Given this list of marker genes Slc41a1 (NCBI Gene Id 98396), Trpm7, Kel (NCBI Gene Id 23925), Tmem94, Xk, Edn3, here is a description of the gene set: studied in species Mus musculus Mouse Gene Set: GOBP_INTRACELLULAR_MAGNESIUM_ION_HOMEOSTASIS A homeostatic process involved in the maintenance of a steady state level of magnesium ions within a cell.